The following is a description of a gene set: Reactome Pathway: Electron transport from NADPH to Ferredoxin electronically inferred by orthology from the curated human pathway part of: Mitochondrial iron-sulfur cluster biogenesis This event has been computationally inferred from an event that has been demonstrated in another species.<p>The inference is based on the homology mapping from PANTHER. Briefly, reactions for which all involved PhysicalEntities (in input, output and catalyst) have a mapped orthologue/paralogue (for complexes at least 75% of components must have a mapping) are inferred to the other species. studied in species Mus musculus, and this is the list of marker genes: Fdxr, Fdx2, Fdx1